The following is a description of a gene set: Human Gene Set: GOMF_FRUCTOSE_2_6_BISPHOSPHATE_2_PHOSPHATASE_ACTIVITY species: Homo sapiens Catalysis of the reaction: D-fructose 2,6-bisphosphate + H2O = D-fructose-6-phosphate + phosphate., and this is the list of marker genes: PFKFB3 (6-phosphofructo-2-kinase/fructose-2,6-biphosphatase 3), PFKFB2, TIGAR, PFKFB1, PFKFB4